Given this list of marker genes TPST1, CDK5R1, EIF3L, SEC24A, UBE2N, SRD5A3, LSM12, PSMC2, ATP5F1A, FBXW7, SNX1, ATP5MC1, MYO5C, TRAP1, ZC3H14, DUSP3, SLC30A9, RAB2B, SLC25A33, PRX, ABHD14A, NCAM2, ABHD5, RPN2, RAB2A, NCF4, FMO4, PTPRJ, CCDC115, PDXDC1, GABRA5, VAV2, LPCAT3, FZD7, BMPR1A, PNP, MGAT2, TOX2, ACSF3, NUP155, KHSRP, PIH1D1, FHL2, LTB, MAGI3, ZFAND4, XRCC5, NSMCE2, UQCC1, GARIN5B, RPRD1B, CCDC122, EIF2S1, SMYD1, PPP2R1B, PPP1R2, CYP20A1, MMACHC, PPP1R15B, TOR2A (NCBI Gene Id 84633), SPATA7, LSM4, MGAT4A, REXO2, TSEN2, RAPSN (receptor associated protein of the synapse), COX7B, NT5C, RXRA, STEAP1, DLEU2, NUFIP1, OGFR (opioid growth factor receptor), GUSB, RNPEP, ANO3, MIF, RANBP3L, TSFM, CRIP2, EXOSC9, SLC25A3, CRYBB1, SSR2, SUGT1, CCHCR1, ERGIC3, S100A13, DDOST, PLK3, MGMT, EIF5A, NME7, RPL9, ASB2, ELOVL6, MRPS18A, LY6G5B, PACSIN2, IPO11, PCBP1, PPP4C (NCBI Gene Id 5531), HK1, PRKAR2A, CCNH, SLC52A1, NHP2, TBC1D19, PEX2, BIRC3 (baculoviral IAP repeat containing 3), TBCD, MMP9, SF3A1, ABAT, ZC3H7B, FAM3B, WDR18, TMPRSS7 (transmembrane serine protease 7), EXOC6B, GEMIN4 (gem nuclear organelle associated protein 4), PUS1, MIR20A, FUT7, KPTN, UTP15, ABHD10, AP1S3, LGSN, NLRP2, ALDOA, ANAPC5, MTPN, TMEM14A, SEMA7A, U2AF1, OLFML1, OMP, SNX27, CLPTM1L, PLEKHA4, ERP44, MRTO4, ARL6IP4, GCSH, RANGRF, EEF1AKMT1, PCDH15, HSPBP1, LYPLA2 (lysophospholipase 2), NAT10, C1QTNF6, FRMD4B, COBLL1, KATNB1, TMSB4X, GPS1, TBRG4, here is a description of the gene set: from publication Chessler AD, Unnikrishnan M, Bei AK, Daily JP, Burleigh BA (PMID 19201883) species: Homo sapiens Genes up-regulated in skin from INFG knockout mice after injection of: control versus Trypanosoma cruzi (strain Y). Human Gene Set: GSE13522_CTRL_VS_T_CRUZI_Y_STRAIN_INF_SKIN_IFNG_KO_UP To investigate the early host response triggered by three different strains of Trypanosoma cruzi at a local infection site, changes in host gene expression were monitored in a murine intradermal infection model using Affymetrix oligonucleotide arrays. Robust induction of IFN-stimulated genes (ISGs) was observed in excised skin 24 hours post-infection where the level of ISG induction was parasite strain-dependent with the least virulent strain triggering a muted IFN response. Infection of mice immunodepleted of IFNγ-producing cells or infection of IFNγ-deficient mice had minimal impact on the IFN response generated in T. cruzi infected mice. In contrast, infection of mice lacking the type I IFN receptor demonstrated that type I IFNs are largely responsible for the IFN response generated at the site of infection. These data highlight type I IFNs as important components of the innate immune response to T. cruzi the site of inoculation and their role in shaping the early transcriptional response to this pathogen. We used microarrays to detail the local host transcriptional response to intradermal T. cruzi infection in WT mice and mice depleted of NK cells, or deficient in IFN-gamma or type I IFN responses. Additionally we compared the local host-transcriptional response generated to infection with 3 different strains of Trypanosoma cruzi (Y, Brazil, and G).